Given this list of marker genes PRKAR2B, ABI3BP, ITM2A, GREB1, PWWP3B, HS6ST2, CELF2, ARX, PLCXD3 (NCBI Gene Id 345557), OGN, SELE, PLN, MAOB, here is a description of the gene set: Human Gene Set: LU_TUMOR_VASCULATURE_DN Therapeutic strategies based on antiangiogenic approaches are beginning to show great promise in clinical studies. However, full realization of these approaches requires identification of key differences in gene expression between endothelial cells from tumors versus their normal counterparts. Here, we examined gene expression differences in purified endothelial cells from 10 invasive epithelial ovarian cancers and 5 normal ovaries using Affymetrix U133 Plus 2.0 microarrays. More than 400 differentially expressed genes were identified in tumor-associated endothelial cells. We selected and validated genes that were overexpressed by 3.6- to 168-fold using real-time reverse transcription-PCR and/or immunohistochemistry. Among these, the polycomb group protein enhancer of Zeste homologue 2 (EZH2), the Notch ligand Jagged1, and PTK2 were elevated 3- to 4.3-fold in tumor-associated endothelial cells. Silencing these genes individually with small interfering RNA blocked endothelial cell migration and tube formation in vitro. The present study shows that tumor and normal endothelium differ at the molecular level, which may have significant implications for the development of antiangiogenic therapies. studied in species Homo sapiens from publication Lu C, Bonome T, Li Y, Kamat AA, Han LY, Schmandt R, Coleman RL, Gershenson DM, Jaffe RB, Birrer MJ, Sood AK (PMID 17308118) Genes down-regulated in endothelial cells derived from invasive ovarian cancer tissue.